Given this list of marker genes Lrrc7, Eif4b, Otof, Gnat1, Focad, Igf2bp2, Sash1, Lurap1, Atxn1, Mtcl2, Mip, Pacs1, Kpna6, Nfat5, Rnf152, Rgs20, Got2, Chd3, Ccdc32, Thsd7a (thrombospondin, type I, domain containing 7A), Matcap1, F9, Sncb, Setd7, Lax1, Mucl2, Rsl24d1, Atp1a3, Wnt4, Fbxw8, B3gat2, Nnat, Klk4, Rpp40, Zfp395, Hdgf, Ndufa2, Scrn3 (NCBI Gene Id 99245), Iffo2, Gigyf2, Shisa6, Samhd1, Zfp36l1, Frs2, Slc4a8, Galnt17, Tfdp2, Dnajb2, Trim58, D2hgdh, Rbm20, Banf1, Eya3, 6430548M08Rik, Mul1, Cyyr1, Tbc1d22b, Rprd2, Gadd45gip1, Hnrnpll, Prickle2, Eif4e1b, Psmg2, Il17re, Rab5b, Astn2, Limd2, St3gal1, Rnf150, Tppp, Mapre1, Wiz, Tspan9, Fam171a1, Mdga2, Fgfr1, Zfp26, Prdm2, Ifi203, Pak3 (p21 (RAC1) activated kinase 3), Nkain2, Lpar2, Syn3, Ankrd63, Cops7b, Ap1s3, Syp, AI837181, Dusp2 (NCBI Gene Id 13537), Tbcel, Dhx40, Sh3gl2, Frmd5, Msi2, Itsn1, Aqp6, Nr2c1, Vti1a, Aoc3, Chst1, Flrt2, Cux2, Plxna4, Creb3l1, Crp, Arf3, Ldlrad3, Fmo5, Zfp64, Pakap (paralemmin A kinase anchor protein), Atp1b2, Bsn, Mycl, Rho, Septin3, Rpgr, Naa60, Kansl1 (NCBI Gene Id 76719), Zc3hav1l, Mecp2, Kcnj10, Nectin1, Grip1 (NCBI Gene Id 74053, glutamate receptor interacting protein 1), Gas7, Nedd4l, Wdtc1, Erv3, Srp54c, Dtx4, Prelp, Slc9a8, Htt, Bard1 (BRCA1 associated RING domain 1), Slc25a23, Haus5, Lhx2, Dcaf17, Shmt2, Taok3, Nbl1, Pianp, Zfpl1, Naga (NCBI Gene Id 17939), Klhl20, Dnal1, Jazf1, Nup205, Serpine1, Gabrg2, Dusp16, Ppbp, Slc7a1, Srp54b, Dusp23, Tmem9, Epb41l4a, Sytl4, Fgf10, Synj2bp, Ptprn, Tmem104, Npnt (nephronectin), Zbtb34, here is a description of the gene set: from publication Chen Y, Wang X (PMID 31504780) species: Mus musculus Mouse Gene Set: MIR_6965_5P Genes predicted to be targets of miRBase v22 microRNA mmu_miR_6965_5p in miRDB v6.0 with MirTarget v4 prediction scores > 80 (high confidence targets).